The following is a description of a gene set: Genes positively differentially expressed in cell type: Macrophage upon treatment with cytokine: IL-33 in mouse lymph nodes in vivo. Mouse Gene Set: CUI_MACROPHAGE_IL33_RESPONSE_UP Cytokines mediate cell-cell communication in the immune system and represent important therapeutic targets. A myriad of studies have highlighted their central role in immune function, yet we lack a global view of the cellular responses of each immune cell type to each cytokine. To address this gap, the authors created the Immune Dictionary, a compendium of single-cell transcriptomic profiles of more than 17 immune cell types in response to each of 86 cytokines (>1,400 cytokine-cell type combinations) in mouse lymph nodes in vivo. A cytokine-centric view of the dictionary revealed that most cytokines induce highly cell-type-specific responses. For example, the inflammatory cytokine interleukin-1β induces distinct gene programmes in almost every cell type. A cell-type-centric view of the dictionary identified more than 66 cytokine-driven cellular polarization states across immune cell types, including previously uncharacterized states such as an interleukin-18-induced polyfunctional natural killer cell state. from publication Cui A, Huang T, Li S, Ma A, Pérez JL, Sander C, Keskin DB, Wu CJ, Fraenkel E, Hacohen N (PMID 38057668) species: Mus musculus, and this is the list of marker genes: Sdc4, Scimp, Ifi204, Ccl2, Ncl, Il1b, Ifi47, Serpina3f, Socs1, Nabp1, Atp6v1b2, Isg15, Gnpnat1, Steap4, Serpina3g, Pdcd1lg2, Clec4n, Rars1, Ell2, Ccl12 (C-C motif chemokine ligand 12), Ccl7, Ccl9, Ranbp2, Irf7